Given this list of marker genes JUNB, RCAN2, IL2RA, IL3, FOSL1, PPP3CA, NFATC3, NFATC1, RCAN1, PPP3CB, NFATC2, IFNG, PTGS2, BATF3, JUN, FASLG, FOS, CD40LG, PPP3R1, PRKACA, CHP1, IL4, CSF2, IL2, CABIN1, POU2F1, FKBP1A, AKAP5, here is a description of the gene set: species: Homo sapiens Human Gene Set: PID_TCR_CALCIUM_PATHWAY Calcium signaling in the CD4+ TCR pathway from publication Schaefer CF, Anthony K, Krupa S, Buchoff J, Day M, Hannay T, Buetow KH (PMID 18832364)